The following is a description of a gene set: from publication Cao J, O'Day DR, Pliner HA, Kingsley PD, Deng M, Daza RM, Zager MA, Aldinger KA, Blecher-Gonen R, Zhang F, Spielmann M, Palis J, Doherty D, Steemers FJ, Glass IA, Trapnell C, Shendure J (PMID 33184181) Human Gene Set: DESCARTES_FETAL_KIDNEY_STROMAL_CELLS The gene expression program underlying the specification of human cell types is of fundamental interest. The study authors generated human cell atlases of gene expression and chromatin accessibility in fetal tissues. For gene expression, the study authors applied three-level combinatorial indexing to >110 samples representing 15 organs, ultimately profiling ~4 million single cells. The study authors leveraged the literature and other atlases to identify and annotate hundreds of cell types and subtypes, both within and across tissues. Our analyses focused on organ-specific specializations of broadly distributed cell types (such as blood, endothelial, and epithelial), sites of fetal erythropoiesis (which notably included the adrenal gland), and integration with mouse developmental atlases (such as conserved specification of blood cells). These data represent a rich resource for the exploration of in vivo human gene expression in diverse tissues and cell types. Marker genes curated from the annotated cluster as represented in the Descartes Human Gene Expression During Development database. studied in species Homo sapiens, and this is the list of marker genes: CADM3, COL12A1, LINC01850, COL1A2 (NCBI Gene Id 1278), GDF6, HTRA3, ECRG4, SLITRK2, DKK2, TPPP3, SULF1, PTX3, TBX15, COL6A6, IGF1, WNT2B, ARHGAP20, GREM1, PCOLCE2 (procollagen C-endopeptidase enhancer 2), COL5A3, LOX, ENSG00000248540, FIBIN, RXFP2, NRK, P2RX3, PRELP, LINC01886, MPZ, CTNNA2, DSC3, RASL12, PI15, DPT, IGFBP6, ABCA8, CCL19, EBF3, GAP43, FXYD1 (FXYD domain containing ion transport regulator 1), ANGPTL1, CHRDL1, NRXN2, DLK1, EBF2, MGP, TNFSF11, FGF18, OSR2, LINC02447, MAFA, ENTPD2, COL1A1, SPARCL1, LUM, WIF1, SFRP2, CPA4, LPL, RPRM, OMD (NCBI Gene Id 4958), PSORS1C1, PLP1, APOD, AGT, C1R, REM1, C10orf105, AOX1, DSEL, FBN1, THBS2, PODN, C1QTNF2, MEDAG, MAN2A1-DT, PLAC9, ISLR, LVRN, ADAMTS4, TIMP4, FBLN2, FOXP2, PRSS35, MXRA5, LINC02802, DMRT2, OSR1, NUPR1, ASPN, PCSK9, WNT2, FGF16, SLC6A4, ACTG2, SCARA5, NEGR1-IT1, SLITRK1, ADAMTSL4, DCLK1, F10, MGAT4C, ENSG00000223786, ANGPTL2, PTPRT, PI16, TMEM92-AS1 (TMEM92 antisense RNA 1), SERPINF1, DCN, AHNAK2, EYA2, SLC22A3, SLC7A10, CRYAB (crystallin alpha B), OLFML2B, NGFR, LUZP2, IGFN1, ISLR2, RNASE4, KCNA1, FDCSP, COL3A1, SOD3, ADAMTSL3, COL14A1, OGN, CCN3, PRRX1, KDELR3, LTBP2, POSTN, CNTNAP4, SPARC, WNT10B, MFAP5, CBLN4, HSPB2, TNFAIP6, TMEM229A, LINC02643, PLAAT5, SRPX, LINC00323, ABCC12, FNDC1